The following is a description of a gene set: Mouse Gene Set: GOCC_FC_RECEPTOR_COMPLEX A protein complex composed of a subunit or subunits capable of binding the Fc portion of an immunoglobulin with additional signaling components. The complex functions as a receptor for immunoglobulin. studied in species Mus musculus, and this is the list of marker genes: Fcgr4, Cd247, Pira2, Lilra6, Ms4a2, Pira13, Pira12, Fcer1g (Fc receptor, IgE, high affinity I, gamma polypeptide)